The following is a description of a gene set: Genes down-regulated in comparison of SP1 thymocytes versus SP4 thymocytes. from publication Teng F, Zhou Y, Jin R, Chen Y, Pei X, Liu Y, Dong J, Wang W, Pang X, Qian X, Chen WF, Zhang Y, Ge Q (PMID 22022412) After positive selection in the thymus, the newly generated single positive (SP) thymocytes are phenotypically and functionally immature and undergo apoptosis upon antigen stimulation. In the thymic medullary microenvironment, SP cells progressively acquire immunocompetence. Negative selection to remove autoreactive T cells also occur at this stage. We have defined four subsets of CD4 SP, namely, SP1, SP2, SP3, and SP4 that follow a functional maturation program and a sequential emergence during mouse ontogeny.We used microarray to detail the global programm of gene expression during the maturation of murine CD4 single positive thymocytes Human Gene Set: GSE30083_SP1_VS_SP4_THYMOCYTE_DN studied in species Homo sapiens, and this is the list of marker genes: SRGAP2, ANKH, ST8SIA6, IRF7, PTPN3, GDI2, IFT80, HS3ST3B1, ITGB7 (NCBI Gene Id 3695), MS4A6A, S1PR4, NDRG3, GM2A, PANX1, GBP7, ADGRG5, IFIH1, F2RL1, MCTP2, PPP1R21, CCDC88C, SGSH, XDH, IFI44, TNFSF8, NTRK3, SLC35D2, ALS2, TTC7A, RAB21, TTC39B, IL17RA, TRAF3IP2, DTX3L, RNF32, ATP8A2, DNAJA4, IL6R, PDE3B, NLRC5, SLC66A3, AP1G2 (adaptor related protein complex 1 subunit gamma 2), IER5, DHDH, AMIGO2, SELENOP, PHYHD1, ADAMTS20, GRAMD4, KLHDC2, PCED1B, SLC30A7, SMURF2, CD44, LY75, RASA3, CRLF3, GNE, TGFBR2, PIGQ, AHNAK, SGK1, SCFD2, UBASH3B, ADGRE5, TRAFD1, SAMD9L (sterile alpha motif domain containing 9 like), ITGA6, CD200R1L, SIDT1, LMNTD2, NIBAN1, CREBL2, CTSE, IL18R1, ITPK1, IRGM, TBX21, TRIM34, RNF115, B4GALT5, GUCD1, ENDOD1, RFLNB, ATP10D (NCBI Gene Id 57205), KMT2A, ADAM19, IKBKE, PARN, RRM2B, APPL2 (adaptor protein, phosphotyrosine interacting with PH domain and leucine zipper 2), C19orf12, APP, CTSW (NCBI Gene Id 8849), IKZF3, HVCN1, DPY19L1, ZBTB16, IGFBP4, CRTAM, ABTB3, PNPLA7, SELPLG, MYD88, FAAH, TBC1D16, TAP1, S1PR1, VIT, SPAG9, OAS1, TMEM175, NBEAL1, NOD1, ALS2CL, TMEM71, HERC6, TMIE, KLF2, TDRD7, ZBTB25, LDLRAP1, AKR1C2, ESRP2, DSE, MANBA (NCBI Gene Id 4126), PRKDC (NCBI Gene Id 5591), SPN, TENT5C, MADD, IGFLR1, SLC25A24, FBXL13 (NCBI Gene Id 222235), ATP11B, EHBP1L1, SEMA4F, KLHDC1, C3orf80, SHLD2, RAB3IP, ARSB, ABCA1, RIPOR2, SESN1, AMPD3, PLEKHA2, RPRD2, OAS2, MLYCD, ABCD1, FAM78A, PRMT3, ACSBG1, CRMP1, IPCEF1, DAPL1, PLEKHM3, TTC27, NCMAP, STAT3, DTX1, CCDC102A, MKNK1, SLC12A7, PXYLP1, MAP3K5, CLCF1, DNAH8, C5, SMPDL3A, RHOQ, CTSS, ZNF536, CYB561A3, TRAF5, NXPE3, ADCY7, SNTB2, SYNE2, ADD3, KLF3, IFITM10, ANKRD12, MAN1C1, IL21R, NT5E, INF2, CDIPT, NUP210, RNF213, PPP3CC, GGT1 (NCBI Gene Id 91347), TTC13, MAF, TBC1D1, TLR1, CYP4V2, FAM234A, IL2RB, OASL